The following is a description of a gene set: Genes having at least one occurrence of the motif MKCCCSCNGGCG in the regions spanning 4 kb centered on their transcription starting sites. This matches the GTF3A transcription factor binding site V$AP2_Q6 (v7.4 TRANSFAC). Human Gene Set: AP2_Q6 studied in species Homo sapiens, and this is the list of marker genes: CYTH2, FAM53C, ASS1, PPM1J, TSPAN2, PCIF1, SMARCD2, CNP, VPS35, TMTC2, TMEM178A, SOX12, TNFAIP8L3, MNT, BAHD1, MAGIX, ENHO, GALNT10, GGNBP2, PLCB3, RASIP1, BSN, HCN1, GSE1 (NCBI Gene Id 23199), APLP1, BANP, USP48, SOBP, RASA1, TEAD2, FXR2, SOX2, MMD, PABPC3, HPN, ZNF593, SFXN2, TRIM39 (NCBI Gene Id 56658), GRK5, CREB3, RGS9BP, CBX6, ZDHHC14, PRR7, CAMK4, FAF1, PLXNC1, HMGN2, KICS2, FKBP14, SPATA6, CYB5R1 (NCBI Gene Id 51706), CAMTA2, EPHB1, DUSP15, LHX2, ZNF513, RAB10, DAGLA, FNBP1L, UBTF, PDZD7, ATXN7L2 (ataxin 7 like 2), C6orf62, IQUB, RBM15B, CDC73, ZFAND3, CEND1, GPC4, NOTCH3, APBA1, PDE5A, SLC30A5, MAFB, ATP5MC2, ALG5, DNTTIP1, CPEB4, GUCY1A2, MBD3, PLEKHA8, HS3ST3B1, NXPH3, ANGPTL2, GPR3, HDLBP, GATA2, CNNM1, PPP2R5E, ACTR1A, AKIRIN2, ZDHHC2, VEGFB, CTNND2, DCUN1D3, EP300, EDA, GAS7, WAC, NFKBID, MYADM, MARCKSL1, NIBAN1, CRLF1, CRBN, NRF1, EFEMP2, ST8SIA2, SDC1, IGFBP7, LIMD2, PHF21B, SMOX, GLTP, NYAP1, MTA2, CREB3L1, RPRD2, BRPF1, C6orf89, CDK9, ZNF341, INSM1, CTCF (CCCTC-binding factor), TMEM256, RAB22A, AMMECR1L, MAPRE3, RASGRP2, RAPGEFL1, RASAL2, KLC2, ARID1A, POLD3, PDGFB, RAP1GDS1, SLC25A12, LCOR, SHB, SLC25A28, RCOR2, HAPSTR1, SPCS2 (signal peptidase complex subunit 2), PBX3, PPM1E, RAB3IP, TMEM8B, TERF2, MED13, MAST2, SPRY2, KAT7, PRR16, TLN1, GALNT14, EBAG9, CDK8, PAX2, MAPRE1, TBX2, ACTB, STAG2, ORC6, ZZZ3, SUFU, CCDC71, H1-0, MARCHF6, CNNM4, WNT7A, KCNN2, LDB1, MED26 (NCBI Gene Id 9441), CARF, CDC25A, NRG1, HCST, ZNF644, UBE2S, ANKRD13B, PLAGL2, ARHGAP36, PABPC1, SLC7A10, IRF1, SFRP2, SPPL3, LMX1A, ARHGAP5, FZD5, RAB35, SPTBN4, PPFIA1, ANKRD27, HOXB2, ZNF503, CADM1, ACTL6B, SP4, SALL1, CLC, EXOSC8, LYRM1, BCL3, COL11A2, TEX2, SPTB, MAPK6, PPP6C, ARPC1A, ATP5PD, PCGF5 (polycomb group ring finger 5), TRIM28, CENPB, ICA1 (NCBI Gene Id 3382), ATL2, USP49, WNK1, RRBP1, KCNH5, CNNM2, WFDC3, UBE2B, SIRT1, DNAI1, PHF12, MIR17HG, KY, TMEM59L, POFUT1, E2F3, HOXA6, FST, WNT3, LHX1, PITX3, ATF7IP, POU2F1, WDR12, SP3, REV3L, CEP95, FGF11, GATA6, BCL2, KDM2A, DDX5, RELB, CCDC177, CRK, MEIS2, FBXO11, GPBP1, FMNL1, CELF1, WNT1, DNMT3A, ZNF362